Given this list of marker genes Pts, Gch1, Calm1, Gchfr, here is a description of the gene set: studied in species Mus musculus This event has been computationally inferred from an event that has been demonstrated in another species.<p>The inference is based on the homology mapping from PANTHER. Briefly, reactions for which all involved PhysicalEntities (in input, output and catalyst) have a mapped orthologue/paralogue (for complexes at least 75% of components must have a mapping) are inferred to the other species. Reactome Pathway: Tetrahydrobiopterin (BH4) synthesis, recycling, salvage and regulation part of: Metabolism of cofactors electronically inferred by orthology from the curated human pathway